Given this list of marker genes Gas8, Krtap11-1, Rsrc1, Gpr34, Kpna4 (karyopherin subunit alpha 4), Kcns3, Colq, Prodh, Rnf111, Zfp704, Htr2c, Batf, Mest, Clec18a, Col13a1, Mfhas1, Ncapg2, Itga3, Sod2, Fndc3b, Meis2, Ift80, Gabrg2, Mmp2, S1pr3, Col4a3, Yipf6, Rnf14, Prx, Ski, Tmem165, Tmem50b, Zfp2, Rasal2, Xpo1, Nat8f2, here is a description of the gene set: Genes predicted to be targets of miRBase v22 microRNA mmu_miR_6362 in miRDB v6.0 with MirTarget v4 prediction scores > 80 (high confidence targets). studied in species Mus musculus from publication Chen Y, Wang X (PMID 31504780) Mouse Gene Set: MIR_6362